Given this list of marker genes LMNA, FRG1, RIPK4, KMT2D, HNRNPK, ZMPSTE24, ECEL1, HOXB1, NGLY1, DLX4, PRR12, DUX4, SMCHD1, CTNND1, DNMT3B, DUX4L1, KDM6A, POLR3A, CDH1, MYMK, here is a description of the gene set: A condition in which the eyelids do not close to cover the eye completely. Lagophthalmos species: Homo sapiens Human Gene Set: HP_LAGOPHTHALMOS